The following is a description of a gene set: Mouse Gene Set: MIR_216A_5P Genes predicted to be targets of miRBase v22 microRNA mmu_miR_216a_5p in miRDB v6.0 with MirTarget v4 prediction scores > 80 (high confidence targets). studied in species Mus musculus from publication Chen Y, Wang X (PMID 31504780), and this is the list of marker genes: Cdkl2, Klf9, Tmem161b, Pfkfb3, Tmem255a, Ranbp10, Mtmr2, Ramacl, Snip1, Tob1, Cpeb4, Itch, Nhlh2, Cbll1, Tmem170, Yeats2, Hmgb1, Tcp11l2, Rlig1, Htr2c, Col4a4, Rasa2, Pdcd10 (NCBI Gene Id 80414), Ttc9, Chmp1b, Zfp667, Prr5l, Oard1, Ccnj, Ric8b, Cxxc4, Zbtb2, Zfp653, Ssx2ip, Ap1s2, Spink5, Klf8, Egr3, Rc3h1, Dennd6a, Cpsf6, Arhgap20, Cadm2, Leo1, Zfp26, Smim9, Zkscan14, Pygo1, Lrrc4c, Neo1, Strn, Arid1a, Insm2, P2ry12, Pcdhb4, Gnl3l, Taf7l, Nmu, Trim32, Adgrg6, Kpna3, Morc3, Srsf10, Nsmce2, Rbms3 (NCBI Gene Id 71506), Mysm1 (NCBI Gene Id 320713), Dgkb, Psg22, Rgs13, Csk (NCBI Gene Id 12988), Jak2, Sntg1, Rab40b, F2r, Mapk1ip1l, Mmp16, Sde2, Ramac, Fasl, Exph5, Dazap1, Atg12, Cmtr2, AW554918, Napg, Rsbn1